Given this list of marker genes LRPPRC, MT-ND3, TRUB2, MT-ND2, MT-CO3, RPUSD3, MTERF3, FASTKD2, NGRN, RCC1L, MT-ND1, MT-ND5, MTPAP, MT-ND6, TRMT61B, MT-ND4L, MT-CYB, SLIRP, MT-CO2, MT-ND4, MT-ATP8, RPUSD4, MT-CO1, MT-ATP6, here is a description of the gene set: Mitochondrial mRNAs contain polyadenylation, pseudouridylation, and N1-adenosine methylation, posttranscriptional modifications that are catalyzed by proteins encoded in the nucleus. <br>Polyadenylation at the 3' ends of mitochondrial mRNAs is produced by MTPAP (also called PAPD1), a dimeric polyadenylate polymerase located in both the cytosol and the mitochondrial matrix. Like the polyadenylate tails of cytoplasmic mRNAs, the mitochondrial polyadenylate tails appear to stabilize the mRNAs, however, mitochondrial polyadenylate tails (~40-50 adenylate residues) are shorter than those observed in the cytosol (~250 adenylate residues). MTPAP may also catalyze polyuridylation. <br>Pseudouridylation in mitochondria is catalyzed by a large protein complex, the mitochondrial pseudouridylation module, that contains the pseudouridine synthases RPUSD3, RPUSD4, and TRUB2. RPUSD4 pseudouridylates rRNA and tRNA while either RPUSD3 or TRUB2 are capable of pseudouridylating uridine-390 of MT-CO1 mRNA and uridine-697 of MT-CO3 mRNA. Depletion of either RPUSD3 or TRUB2 caused a reduction in mitochondrial translation. <br>In mitochondria, methylation of the N1 position of adenosine residues in mRNAs is catalyzed by the methyltransferase TRMT61B, which methylates adenosine residues in the MT-ND1, MT-CO1, MT-CO2, MT-CO3, MT-ND4L, and MT-CYB mRNAs. N1-methyladenosine in mitochondrial mRNAs causes ribosome stalling and reduced translation. studied in species Homo sapiens part of: Metabolism of RNA Reactome Pathway: Mitochondrial mRNA modification